The following is a description of a gene set: studied in species Mus musculus from publication Chen Y, Wang X (PMID 31504780) Mouse Gene Set: MIR_7663_5P Genes predicted to be targets of miRBase v22 microRNA mmu_miR_7663_5p in miRDB v6.0 with MirTarget v4 prediction scores > 80 (high confidence targets)., and this is the list of marker genes: Itgb2, Fam185a (family with sequence similarity 185, member A), Rc3h2, Btbd1, Tmed2, Slitrk5, Slc17a2, Strap, Usp48, Strn, Nfat5, Fam168a, Gxylt1, Hoxd3, Spp1, Kdm5a, Igf1r, Klhl24, Cacul1, Tmed9, Eif4g2, Amer1, Osbpl6 (NCBI Gene Id 99031), Rapgef4, Dcdc2a (NCBI Gene Id 195208), Rnf169, Cd53, Lrrc42, Rab8b, Usp24, Mef2a, Rel, Tmem70, Rai2, Slc39a12, Fam210a, Taok1, Stag2, Pou5f2, Onecut2, Slc40a1, Vamp4, Adgre1, Pcdh20, Fut9, Foxo3, Gabpa, Vwde (NCBI Gene Id 232585), Dsg3, Smco3, Slc4a4, Pkn2, Reps2, Mecp2, Tead1, Fbxo32, Rbbp5, Mis18bp1, Slc22a23, Hmgcll1 (3-hydroxymethyl-3-methylglutaryl-Coenzyme A lyase-like 1), Caskin2, Gpr4, Naaladl2, Fsd1l (fibronectin type III and SPRY domain containing 1-like), Mamld1, Parp9, Sertad2, Nek6, Pde1c, Scn8a, Man1a2, Acyp2, Chchd6, Slc35e1, Frrs1l